The following is a description of a gene set: A protein complex that catalyzes the deneddylation of proteins, including the cullin component of SCF ubiquitin E3 ligase; deneddylation increases the activity of cullin family ubiquitin ligases. The signalosome is involved in many regulatory process, including some which control development, in many species; also regulates photomorphogenesis in plants; in many species its subunits are highly similar to those of the proteasome. Human Gene Set: GOCC_COP9_SIGNALOSOME studied in species Homo sapiens, and this is the list of marker genes: HSPA7, EPB41L2, SLA, HSPA1A, PLCG1, GPS1, COPS7A, COPS2, GRB2, HSP90AB1, DYNLL1, WDR6, BASP1, COPS6, COPS8, COPS3, TESPA1, AMOTL1, HSPA1L, THEMIS, HSPA5, HSPA6, TMOD1, FLOT1, MYH9, DOCK7, AMOT, LAT, GRAP, COPS7B, COPS4, NCKIPSD, DCAF1, COPS5, COPS9